Given this list of marker genes Mff, Triap1, Tmem14a, Bcl2a1c, Camk2a, Hk2, Bcl2l2, Rhot1, Eya2, Plaur, Mul1, Naif1, ENSMUSG00000126352, Pnp, Atp5if1 (ATP synthase inhibitory factor subunit 1), Gsk3b, Pycard, Jtb (jumping translocation breakpoint), Stpg1, Pla2g6, Acaa2, Vps35, Ppm1k, Slc25a5, Pdcd5 (programmed cell death 5), Hrk, Sod2, Mcl1, Hspd1, Rhot2, Nptx1, Cdkn2a, Slc25a4, Ggct, Avp, Ccar2, Pmaip1, Plscr3 (NCBI Gene Id 70310), Dap3, Vdac2, Parl, Mir361, Chchd10, Bak1, Pink1, Tmem102, Hgf, Map3k1, Prkn, Ppp2cb, Tnfsf10, Fam162a, Fzd9, Mapk9, Them4, Gsk3a, Mllt11, Bik, Opa1, Cd24a, Bnip3l, Bad, Timm50, Bmf, Ppif, Hip1r, Atp7a, Dnm1l, Mfn2, Mmp9, Smad3, Mtch2, Gclm, Igf1, Prelid1, Bcl2a1b, Gclc, Bcl2l10, Zfp13, Slc35f6, Lmna, Aifm2, Ppp2r2b, Bcl2l1, Fxn, Arrb2, Moap1, Jun (jun proto-oncogene), Fmc1, Ier3, Nol3, Bcl2, Wdr35, Akt1, Sfn, Higd1a, Ghitm, Pim2, Bid, Cck, Fis1, Trp53, Siva1, Slc25a31, Atp2a1, Bnip3, Bcl2l11, Rnf7, Bok, Gpx1, Mpv17l, Bloc1s2, Bax, Psmd10, Atg3, Fas, Erbb4, Aifm1 (apoptosis-inducing factor, mitochondrion-associated 1), Ndufs1, Bcl2a1d, Bbc3, Atf2, Pdcd5-ps, Gper1, Bcl2a1a, here is a description of the gene set: species: Mus musculus Mouse Gene Set: GOBP_APOPTOTIC_MITOCHONDRIAL_CHANGES The morphological and physiological alterations undergone by mitochondria during apoptosis.